The following is a description of a gene set: Human Gene Set: GOBP_SLEEP Any process in which an organism enters and maintains a periodic, readily reversible state of reduced awareness and metabolic activity. Usually accompanied by physical relaxation, the onset of sleep in humans and other mammals is marked by a change in the electrical activity of the brain. studied in species Homo sapiens, and this is the list of marker genes: NPY2R, CRH, MRGPRX2, GHRH, PTGDS, CSF2, ADRB1, DRD2, PARP1 (NCBI Gene Id 142), GHRL, MTNR1B (NCBI Gene Id 4544), BTBD9, IL18, FXR1, GABRB3, PLN, NMU, ADORA2A, PTGDR, ADORA1, GHRHR, KCNA2, CACNA1I, CHRNB2, HCRT, PER3, GRIN2A